The following is a description of a gene set: The chemical reactions and pathways involving mannose, the aldohexose manno-hexose, the C-2 epimer of glucose. The D-(+)-form is widely distributed in mannans and hemicelluloses and is of major importance in the core oligosaccharide of N-linked oligosaccharides of glycoproteins. Human Gene Set: GOBP_MANNOSE_METABOLIC_PROCESS species: Homo sapiens, and this is the list of marker genes: MAN2C1, MAN2A1 (mannosidase alpha class 2A member 1), MAN2B2, PMM1, MAN2B1, MAN2A2, GMPPB, PMM2, MPI, HK1